Given this list of marker genes STX4 (syntaxin 4), PRKCB, PRKCG, PRKCA, STXBP3, here is a description of the gene set: part of: Response to elevated platelet cytosolic Ca2+ The SNARE (SNAp REceptor) family of proteins are critical components of the machinery required for membrane fusion. SNAREs can be grouped into three broad subfamilies: synaptosomal-associated proteins (SNAPs), vesicle-associated membrane proteins (VAMPs) and syntaxins. SNAPs contain two SNARE motifs and lack transmembrane domains, instead they are anchored to the membrane by thioester-linked acyl groups. VAMPS or R-SNAREs have two subfamilies: short VAMPs or brevins and long VAMPs or longins. Syntaxins are evolutionarily less-well conserved, but except STX11 are transmembrane proteins. Several SNARE proteins including Syntaxin-2 (STX2), STX4, STX11 and Vesicle-associated membrane protein 8 (VAMP8) are thought to be involved in platelet granule secretion. Reactome Pathway: Disinhibition of SNARE formation studied in species Homo sapiens